The following is a description of a gene set: Human Gene Set: GSE32986_UNSTIM_VS_GMCSF_AND_CURDLAN_HIGHDOSE_STIM_DC_UP from publication Min L, Isa SA, Fam WN, Sze SK, Beretta O, Mortellaro A, Ruedl C (PMID 22250091) Genes up-regulated in bone marrow-derived dendritic cells: unstimulated versus CSF2 and high dose of 1,3-beta-D-oligoglucan. studied in species Homo sapiens A simultaneous engagement of different pathogen recognition receptors provides a tailor made adaptive immunity for an efficient defence against distinct pathogens. For example, cross talk of TLR and c-type lectin signalling effectively shapes distinct gene expression patterns by integrating the signals at the level of NF-κB. Here, we extend this principle to a strong synergism between the Dectin-1 agonist, curdlan, and an inflammatory growth factor, GM-CSF. Both together act in synergy in inducing a strong inflammatory signature which converts immature DCs to potent effector DCs. A variety of cytokines (IL-1β, IL-6, TNF-α, IL-2 and IL-12p70), costimulatory molecules (CD80, CD86, CD40 and CD70), chemokines (CxCl1, CxCl2, CxCl3, CCl12, CCl17) as well as receptors and molecules involved in fugal recognition and immunity such as Mincle, Dectin-1, Dectin-2 and Pentraxin 3 are strongly up-regulated in DC treated simultaneously with curdlan and GM-CSF. The synergistic effect of both stimuli resulted in strong IKBα phosphorylation, in its rapid degradation and in enhanced nuclear translocation of all NF-κB subunits. We further identified MAPK ERK, as one possible integration site of both signals, since its phosphorylation was clearly augmented when curdlan was co-applied with GM-CSF. Our data demonstrate that the immunomodulatory activity of curdlan requires an additional signal provided by GM-CSF to successfully initiate a robust β-glucan specific cytokine and chemokine response. The integration of both signals clearly prime and tailor a more effective innate and adaptive response against invading microbes and fungi., and this is the list of marker genes: EME1, GAB2, MAPKAPK3, MAGED1, CDK5RAP2, KIF24, NUF2, RNF19B, STK39, RNASEK, LPCAT3, AK4, LRRC42, FASN, CMAHP (NCBI Gene Id 8418), VLDLR, PDXDC1, POLD1, SLC15A4, DCAF7, KIF18B, BCL2L1, PCBD1, TXN, NABP2, PKMYT1, RRM2, HUS1B, TIPIN, TUBA1C, TOPBP1, SETD7, PSMG1, EMC9 (ER membrane protein complex subunit 9), TRAIP, COPG1, ZG16B, CTPS1, KCNAB2, WARS1, IFI27L2, ADAM9, CENPM, CHP1, MTCH2, TPGS2, RECQL4, NDUFB4, TJP2, ATP13A3, NME7, ELL2, MED20, FRMD4B, LIMK1, CDCA3, SEC61A2, SYTL3, ZBTB32, DESI2, DMC1, TNFAIP1, BOLA3, RTKN, SEC23A, PSMD1, H4C6, TNFRSF11A, SREBF2, POMP, UNG, FUT8, AP1M1, IL1R2, GARS1, PRKAG1, RHOC, ERAL1, RBM47, RCBTB2, PGM1, KIF4A, TACC1, PSMC3, CD68, SIPA1L1, E2F8, H3C12, IFI27L1, VKORC1L1, KDSR, CPOX, CD63 (CD63 molecule), ZFP64, JAK2, DPY30, SMC2, ARHGAP19, CD2, H1-5, FARSA, YIF1B, TFRC, DUSP10, TDRKH, PREB, SLC31A1, SMCO4, MRPL37, ERG28, NDUFC2, SUSD6, RELB, SECTM1, RNF181, GTDC1, PXMP2, FAH, NFKBIB, RPN1, CHKA, CYB5R3, ICAM1, LACTB, GLB1, TBC1D10B, H2AC21, MVD, ZGRF1, GOT1, NARF, YIPF1, NUP205, PIH1D1, EZR, GALE, DCTN2, TRIB3, PRR5L, MRPL27, HIP1, CLTA, SPIRE1, SLFN11, ODF2, TMEM14C, TMEM135, UBA2, PRICKLE3, C4orf33, STXBP2, SNRPD1, NQO1, TM7SF3, LRR1, PFKFB4, NUP153, F2R, PCGF1, E2F7, MYO1G, RAD54B, MSH6, WEE1, CNTROB, EAF2, MRPL16, H4C13, COX8A, UBE2MP1, TUBB6, DCTPP1, RFC5, RTTN, GALNT3, CD79B, HNRNPUL2, WSB2, DPP3, EBP, CHUK, SDC4, SLC35A2, FBXO5, SIAH2, TRAPPC1, SLC25A44, ADRM1, WDR76 (NCBI Gene Id 79968), JPT1, ATP5MC1P5, HAUS4, SQOR, RHEB, XPO5, ARPC2, RNPEP, PHGDH, SYT11, SCAMP3